Given this list of marker genes DCK, H2AZ1, PRDX1, FKBP3, UBE2E1, SLC25A4, EGR2, TIMP3, BCAP29, RPS24, PREP, GADD45B, RASGRF1, FAH, EPHA7, TPT1, C1QBP, VIM, RPL5, CDC5L, RDX, SELENOP, CCNG1, COL6A2, CASP6, ACTB, PAFAH1B1, MARCKS, GRIA2, TRA2B, SOS2, SCD, MBL1P, here is a description of the gene set: Human Gene Set: JIANG_AGING_CEREBRAL_CORTEX_UP studied in species Mus musculus A better understanding of the molecular effects of aging in the brain may help to reveal important aspects of organismal aging, as well as processes that lead to age-related brain dysfunction. In this study, we have examined differences in gene expression in the hypothalamus and cortex of young and aged mice by using high-density oligonucleotide arrays. A number of key genes involved in neuronal structure and signaling are differentially expressed in both the aged hypothalamus and cortex, including synaptotagmin I, cAMP-dependent protein kinase C beta, apolipoprotein E, protein phosphatase 2A, and prostaglandin D. Misregulation of these proteins may contribute to age-related memory deficits and neurodegenerative diseases. In addition, many proteases that play essential roles in regulating neuropeptide metabolism, amyloid precursor protein processing, and neuronal apoptosis are up-regulated in the aged brain and likely contribute significantly to brain aging. Finally, a subset of these genes whose expression is affected by aging are oppositely affected by exposure of mice to an enriched environment, suggesting that these genes may play important roles in learning and memory. Up-regulated in the cerebral cortex of aged (22 months) BALB/c mice, compared to young (2 months) controls from publication Jiang CH, Tsien JZ, Schultz PG, Hu Y (PMID 11172053)